The following is a description of a gene set: Human Gene Set: GOMF_PHOSPHOPROTEIN_PHOSPHATASE_ACTIVITY species: Homo sapiens Catalysis of the reaction: a phosphoprotein + H2O = a protein + phosphate. Together with protein kinases, these enzymes control the state of phosphorylation of cellular proteins and thereby provide an important mechanism for regulating cellular activity., and this is the list of marker genes: VRK3, ACP1, PPEF2, ELFN1, DUSP29, SSH3, PPP4R2, DUSP26, DUSP9, SLC39A10, PTPN23, HTT, PPP1R15B, DUSP15, MYOZ1, PPP1R14C, MTM1, CTDSP2, PABIR1, PTPRQ, PPM1D, PTEN, DMPK, CAMK2G, PPM1N, PTPRU, PPP1R7, PTPN13, DUSP2 (dual specificity phosphatase 2), PTPN21, PTPRO, MYH6, AMBRA1, PPP2R1B, CDC14A, PPP1R2B, IGBP1, PPP1R9B, CDCA2, PPP2R3B, PPM1L, ACP3, PPM1B, PPP2R5B, PHACTR3, PTP4A3, PPP2R2C, DUSP12, PPEF1, GNA12, DUSP8, PPP3CB, PPP1R1C, PPP3CA, EYA3, PPP2R3A, SAG, PPP1R14D, PPP1CA, PPP1R3C, DUSP19, PALD1, PPP2R5D, DUSP23, PPP1R2C, PPP2CA, DUSP14, CALM2, PPP1R2, PPP3R2, IGFBP3, PPTC7, CABIN1, MTMR14, PPP1R12C, SSU72L5, SSU72, PTPN7, PHACTR4, PTPN11, PABIR2, PHACTR2, PPP1R16A, SSH1, PPP4R3C, CDKN3, PTP4A2, ACP4, PTP4A1, MDP1, PPM1H, MGAT5, PTPA, PHLPP2, CTDSPL, SSU72L3, PPME1 (NCBI Gene Id 51400), PPP1R2P1, PTPRB, CD33, CDC14C, DLG1, TNS2, PTPN2, DUSP7, PTPRD, PTPN1, CRY2, PTPN5, PPA2, PTPRG, TNS1, DUSP22, BOD1, DUSP4, PPP1CB, PPP4C, SSU72L1, ANKLE2, PPP2R1A, DUSP16, SHOC2, CDC25C, PTPRK, PTPRE, RCAN2, VCAN, PPP3CC, PTPRJ, PPM1K, PHPT1, PPP1R1B, PTPRZ1, SSH2, PPP1R14B, DUSP6, TIPRL, DUSP13A, PPP4R3B, PPM1F, PTPN9, PPM1J, LGALS3, PPP1R17, MTMR6, PTPRN2, DUSP18, PTPN20, DUSP5, DNAJC6, B3GAT3, CDC14B (cell division cycle 14B), PPP4R4, PPP2R5E, PTPN22, TAB1, PPP1R12A, PTPMT1, PTPN12, PTPN6, PTPRM, LCK, PTPN4, EPM2A, PABIR3, PTPRR, PPM1E, UBASH3B, DUSP10, PHACTR1, PPP5C, SIRPA (signal regulatory protein alpha), HACD2, PPM1G, PPP1R11, UBLCP1, TPTE, RNGTT, TIMM50, PTK2, MTMR3, FIG4, STYXL2, PPP6R2, CALM3 (NCBI Gene Id 808), CTDSP1, PPP2R5A, PPP1R16B, PTPRH, SH3RF2, ILKAP, PTPRA, PPP2R5C, PPP1R15A, CTDP1, CNEP1R1, HSP90AB1, PTPN18, PTPDC1, PTN, EIF2AK2, DUSP21, DUSP13B, PGAM5, CDC25A, YWHAE, CTDSPL2, PPP1R3D, MYH3, CTDNEP1, MYH8, PPP4R1, PPM1A, PPP6C, CIP2A, MTMR4, DUSP28, YWHAB, PPP1CC, PTPRC, PTPN14, PPP2R2D, ELFN2, EYA1 (NCBI Gene Id 2138), DUSP3, PPP4R3A, RCAN1 (regulator of calcineurin 1), PTPRF, HSP90B1, PPP2R2B, PP2D1, PTPN3 (NCBI Gene Id 5774), PPP1R26, MTMR7, CPPED1, PPP2R2A, SSU72L2, RCAN3 (NCBI Gene Id 11123), DUSP1, PPP1R3B, PGP, PTPRN, PPP1R36, PPP1R14A, BCKDK, PTPRS, EYA2, PPP1R37, ARPP19, TPRN, PPP6R1 (NCBI Gene Id 22870), PDP1, PPP1R8, SET, PPP1R10 (NCBI Gene Id 5514), IGFBP2, DUSP11, PPP1R3E, PPP3R1 (protein phosphatase 3 regulatory subunit B, alpha), SSU72L6, TNS3, PHLPP1, CALM1, PTPRT, SBF1, PPP1R12B, PPP1R35, URI1, PPP1R1A, PDXP (pyridoxal phosphatase), PPM1M, ENSA, EYA4, PDP2, PPP1R27, PPP6R3, CDC25B, LMTK2, PPP2CB, SSU72L4, RPAP2